Given this list of marker genes FRY, BRMS1, TPPP, IFNG, MAPT, PRKAA1 (NCBI Gene Id 5562), NNMT, BEX4, PRKAA2, CCAR2, EP300, here is a description of the gene set: studied in species Homo sapiens Any process that modulates the rate, frequency, or extent of protein deacetylation, the removal of an acetyl group from a protein amino acid. An acetyl group is CH3CO-, derived from acetic acid. Human Gene Set: GOBP_REGULATION_OF_PROTEIN_DEACETYLATION